Given this list of marker genes MYO5A, ACTN4, MYO19, SYNE2, SUN2, FNBP1L, MYO1C, WASL, here is a description of the gene set: Human Gene Set: GOBP_ACTIN_FILAMENT_BASED_TRANSPORT studied in species Homo sapiens The transport of organelles or other particles from one location in the cell to another along actin filaments.